The following is a description of a gene set: Mouse Gene Set: GOBP_MONOATOMIC_ANION_TRANSPORT The directed movement of a monoatomic anion, into, out of or within a cell, or between cells, by means of some agent such as a transporter or pore. Monatomic anions (also called simple anions) are negatively charged ions consisting of exactly one atom. species: Mus musculus, and this is the list of marker genes: Slc26a9 (NCBI Gene Id 320718), Slc1a2, Cldn17, Clcn5, Panx1 (pannexin 1), Cldn4, Slc26a7, Slc26a2, Glra1, Ano5, Aqp6, Slc1a3, Slc22a18, Slc13a1, Clca3a1 (NCBI Gene Id 12722), Gabra1, Gabrr2, Gabrb2, Kcne2, Trpa1, Slc6a1, Nmur1, Ano10, Gabra4, Kcnk1, Slc19a1, Slc6a14, Slc1a1, Slc12a9, Clcn4, Clcn1, Vdac1, Slc17a7, Slco1a4, Slc1a4, Clcn3, Slc12a7, Ano4, Clca2, Slc26a10, Pdzk1, Gabrq, Kcnk2, Clcnka, Slc5a5, Slc26a6, Ttyh1, Ttyh2, Apol11a, Mcoln1, Slc12a8, Chrm5, Clca4a (chloride channel accessory 4A), Lrrc8e, Slc17a6, Glra4, Abcb1b, Slco1a8, Slc4a9, Pcyox1, Lrrc8a, Gabrr1, Slc4a11, Slc25a27, Ano8, Stc1, Slc17a8, Kcnn4, Ano3 (NCBI Gene Id 99077), Slc12a5, Clca1, Gabre, Slc26a11, Gabrg1, Gabrg2, Gopc, Tmc4, Gabrp, Ano1, Gabra6, Slc4a2, Slc12a3, Vdac3, Slc4a4, Vdac2, Slc4a5, Ripk1, Slc1a7 (NCBI Gene Id 242607), Slc26a1, Ucp2, Clcnkb, Clcn7, Bsnd, Rab11b, Car7, Mtor, Mcoln3, Ano6, Gabra5, P2ry4, Slc6a2, Glrb, Gabrd, Prkg2, Mfsd8, Tcaf1, P2ry6, Slc22a6, Pacc1, Clic6, Best2, Clns1a, Gabra3, Ostm1, Ano9, Slc26a3, Tg, Slc4a3, Slc12a2, Ano7, Tspo, Kcnq1, Clic1, Slc4a10, Glra2, Nmur2, Abcc3, Atp8b1, Clcn2, Slc26a5, Slc26a4, Slc12a6, Best1, Gabrg3 (gamma-aminobutyric acid type A receptor, subunit gamma 3), Gabra2, Abcb1a, Slc39a14, Cftr, Slc25a14, Lrrc8d, Oca2, Gabrb3, Slc5a8 (solute carrier family 5 (iodide transporter), member 8), Clca3a2, Slc4a1, Slc12a4, Lrrc8c, Car2, Clic5 (chloride intracellular channel 5), Clic3, Ttyh3, Best3, Clcc1, Gabrb1, Glra3 (glycine receptor, alpha 3 subunit, NCBI Gene Id 14656), Slc12a1, Clcn6, Slc4a8 (NCBI Gene Id 59033), Slc26a8, Ahcyl1, Gpr89, Ano2, P2rx5, Gabrr3, Wnk4, Slc5a6, Clic4, Lrrc8b, Casr, Slc4a7